Given this list of marker genes KLHL9, ZBTB20, MOB4, MTX3, PPP2R1A, ANKRD50, TPM1, TP63 (NCBI Gene Id 8860), CNR1, EEF2K, MCAM, CCDC6, TIMM23B, PHF21A, SELENOT, STAT5A, SLC5A8, RNF216, NACC2, DENND5B, SLC35A1, DONSON, WDR26, HAUS2, SSBP2 (NCBI Gene Id 51492), CCDC184, SLC25A2, ATXN7L3B, ZNF770, SLC1A4, BAZ2A, WDR82, HSPA13, NOS1 (nitric oxide synthase 1), RASL12, NAT8L, HIPK2, ZNF740 (NCBI Gene Id 283337), ADAT2, C3orf80, MAPT, IL36G, SYT17 (synaptotagmin 17), ZNF346, NDC1, BRD3, CDK12, CLN6, CD2AP, JAKMIP3, ASH1L, RNF185, STYK1, MC2R, SOCS6, MEGF9, BTNL9, TCEAL7, PCK1, PUM2, AFDN, FOXJ3, CLEC12A, TRIM45, ZFX, NOTCH2NLA, KCNC4, KCNH5, UGT8 (NCBI Gene Id 7368), ACYP2, TM9SF3, SGIP1, ARHGEF4, ABL2, TNRC6C, ASXL1, STAM2, ZXDA, LY6G5C, QSOX2, BNC2, HOOK1, GABRB2, STBD1, SNAP91, ACVR1, FHOD1, BMF, SLC16A9, ENSG00000275993, HPS4, SMCHD1, MLXIPL, PDK4, SDCBP, FLVCR2, COPS7B, MARF1, COL6A3 (collagen type VI alpha 3 chain), NSD3, PI15, DGKG, GNL3L, CYP1B1, ZNF428 (NCBI Gene Id 126299), EP300, GOSR2 (golgi SNAP receptor complex member 2), PNPT1, PPIP5K2, ZMAT2, ING5, TMEM201, PDE7A, GADL1, LYRM7, BHLHE40, FAR1, ZC2HC1A, OPN5, RECK, FRYL, SRGAP3, PLEKHG7, MTF2, NACC1, ADAMTS3, AKAP11, HLF, PGM2L1, ANKRD44, CEP85L, BMP2, PDGFRA, IGF2R, YIPF4, PAPOLA, TSPAN2, RAI1, PNMA8A, TMC7, SLC7A2, PLEKHH1, ENPP4, PLA2G7 (NCBI Gene Id 7941), CEP350, SERBP1, STARD13, PLA2G4A, UBTF, DNAJB9, PCGF2, MEF2D, ZNF670, PTCH1, DYNC1LI1, EFR3B, AMPD3, ABLIM1, LENG8, RNF138, SEPTIN8, USP7 (ubiquitin specific peptidase 7), SAMD4A, OFD1, SLFN13, MET, TLK2, PDZD4, CEP135, ATAD2, PRR23C, CHRDL1, TUB, LRP8, HIC2, RAB3C, DYNLL2, MED28, AFF1, CLTC, TIGIT, RPRD1A, VSTM2A, COPG2, RASGRP3, IQSEC3, CBX3, KDM5A, MACC1, RDX, PTP4A2, UTY (NCBI Gene Id 7404), SLC6A17, STX1B, SPRY3, MEF2A, RAPGEFL1, SPIN2B, PTGES, DDB1 (damage specific DNA binding protein 1), PLXNC1, ADRB1, PROX1, ZSWIM6, TAL1, LIN28B, NLRP8, PPP1R1C, FGF14, CCDC28A-AS1, SPSB4, COL25A1, TCEAL8, PTPN9, ALDH5A1, PAX7, ATE1, MEF2B, NCOA2 (nuclear receptor coactivator 2), CSMD2, FBXO4, HAPSTR1, PAPPA, SCN4A, YTHDC1, NLRP11, ZNF529, HYCC2, CNTN3, MBOAT2, PNPO, ASAH2B, SLC5A7, TFCP2, SCLT1, CRLF3, DNAJB11, PTPRJ, LEMD3, GID4, NYAP2, CHUK, GPR63, C1orf216, PDE1A, NPTX1, DCAF12 (NCBI Gene Id 25853), SYNPO2, GSK3B, SYTL4, JUND, TNFRSF21 (TNF receptor superfamily member 21), KSR2, PTGFRN, VGLL4, SEC63, LSM14A (LSM14A mRNA processing body assembly factor), STK36, GRIK2, SV2A, P2RY1, WDR3, CYP4B1, SLC6A19 (solute carrier family 6 member 19), KIAA0232, POLR1G, KIF13A, TENT5A, FOXK1, RIMS1, SLC39A2, MTMR9, ZNF536, RTF1, RGS7, CACNB2, NPTXR, KCNK9, ADPRH, SEPTIN3, ZNF483, SIN3A, SATB2 (NCBI Gene Id 80104), NEK7, ZNF557, SPOPL (NCBI Gene Id 339745), PLCXD3, NDUFA5, NFYC, PIAS1, MMS22L, SLC25A37, TFAM, NRG3 (neuregulin 3), ILRUN, UBR3, CCDC186, NDUFS2, TMEM67, SLC25A44, SRF, TNIP3, EPHA5, CNTNAP2, MUC15, SOX9, SRRM4, FXYD6, ARHGAP12, FAM180B, UNC13A, MYADM, RNF38, RNF19A, DOCK4, TMEM79, VAPA, PDP1, USP37, SLC1A5, YWHAQ, SP1, KIF3C, CANX, UQCC1 (NCBI Gene Id 55245), RORA, REEP3, OLFML2B, CISD2, ERO1A, GRIK3, NET1, IL13, NRARP, GEMIN8, SPIRE1, PLCL1, SLC25A46, DTX4, SYT2, BAHD1, NAMPT, RBM41, ZNF33A, CPNE8, DCBLD2, MLLT6, NEURL1B, BACH1, ENO2, PTPN3, SNRK (SNF related kinase), SCN8A, TP53BP1, SYNPO2L, NECTIN4, CSNK1G3, FAM184A, ITGB6, CACNG8 (NCBI Gene Id 59283), MFSD2A, ESM1, ABHD18, NAB1, CDC73, PIGS, PHIP, DIRAS1, EBF2, POLR1F, FAM53C, IBA57, GNA14, MYO16, ZBTB4, DESI2, ELK4, MOB3C, SLC41A2, TNFSF9, TNFSF4, ELOF1, RAP2B, CBX2, PABPC1L2A, SRCIN1, TMEM80, EFNA5, GPR180, MMAB, MBNL3, FBXW11, HMGB2, DCAF7, ZNRF2, CRY2, ADPGK, CREBZF, DNM3, CPA4 (NCBI Gene Id 51200), SKIL, BCL11B, LHFPL4, DOK6, ZC3H12C, BRD10 (bromodomain containing 10), GNA12, SCG2, SH3TC2, CBL, DLGAP4, RAD54L2, DUSP6, BEND7, TPCN1, MBL2, NOS1AP, MOBP, PEAK1, TIPRL, SGPL1, PHF3, LONRF1, KDM4A, ITGAM, WDR5B, MSL1 (MSL complex subunit 1), TRABD2A, ARHGEF10, GAS7, METTL16, SLC11A2, PRUNE2, MAPK14, ZBTB42, GPHN (NCBI Gene Id 57566), ENSG00000255537, ATP13A3, ATP6V0D1, CEMIP2, PRR14L (proline rich 14 like), DSEL, CREB5, SEMA4C, SMAD2, INSR, WDR37, NECAB1, VAT1, SLFN5, TRIM2, SLC2A4RG, USF2, NSD1, CSRNP3, GGA2, PLAU, CADM3 (NCBI Gene Id 57863), PARVA, ATOH8, CCDC9, TMEM245, TMOD2, CACHD1, SLC4A7, COBLL1, BEX4, FAM131A, UBN2, GLCCI1, ZCCHC24, TENT5C, CA12, TBC1D13, SLC7A11 (NCBI Gene Id 23657), PIK3R1, NEO1, FGFR3, MAPKAPK2, MEIS2, LIFR, ANKRD34C, SMIM15, GSTM5, RUNX1, PRDM5, DENND2D, DAAM1, CSNK2A1, TIFA, LBH, OAS3, PLXNA4, KIF2A, ELK3, ZSWIM5, BSN, MINDY2, IL21R, MARCHF8, NDRG4, FBXO5, LRP2BP, RNF112, NKTR, E2F1, MED24, LILRB2, DNAL1, DYRK1A, UNC5C, HIF1AN, FASLG, TENT4B, TRIM44, C2CD2, ADAMTS4 (NCBI Gene Id 9507), NFAT5 (NCBI Gene Id 10725), UHRF2 (NCBI Gene Id 49857), MAP3K9, EYA4, SLAIN2, TBX4, OCLN, ARHGAP26, SPOCK2, ATAD1, ST8SIA1, PAK3, F11R, EPHB3, AK4, PPP2R5C, PRKCA, DPYD, ARMC10, MTCL3, OBI1, WSCD2, FAM174B, CDK6, CDC14A, SHISAL1 (shisa like 1), ADRB3 (NCBI Gene Id 94406), LANCL3, GRID1 (NCBI Gene Id 54547), EAF1, PHKA1, ZHX2, PAX5, IGFBPL1, TMEM178B, PRR27, KDM7A, MON2, CTSV, SSH2 (slingshot protein phosphatase 2), MGAM (maltase-glucoamylase), SSH1, MATN1, SLC8A1, CEP41, ZNF266, WDFY3, FBN1, PCBD2, PTBP2, GJA5, B4GALT1, TMEM196, ZBTB41, ATF7IP, CYLD (NCBI Gene Id 8010), AGPS, GARRE1, SLC6A6, USF3, MVB12B, EDNRA, SEL1L3 (NCBI Gene Id 23231), SORT1, SMG7, FRMD3, FOXL2NB, FLT1, CFAP251, EMC1, BRWD3, KIFC1, ZNF33B, SHISA5, CNOT7, DPYSL2, CLEC4D, SRC, MLXIP, ZMAT3, EFHD2, NRF1, SULF1, CENPBD1P, AMOTL1, BPNT2, ZNF585A, ASCC3, PKIB, POC1B, IGSF9, PALM2AKAP2, KLHL42, CACFD1, SMC5, UBE2H, MRAP2, CHD5, KAT7, DUSP10, GTPBP1, VPS13D, SLC36A1, AJAP1, SLC35A3, TRPS1, MED13 (NCBI Gene Id 9969), PSD4, SORBS2, INO80D, TPGS2, P2RY2, S1PR2, IL17RA, DMXL1 (Dmx like 1), CLRN1, FBXL18, CLASP1 (cytoplasmic linker associated protein 1), KIAA0408, DDHD2, MOSMO (NCBI Gene Id 730593), UNC5A, INKA2, MGAT5, DMC1, BMPER, F2R, RAPH1, RADX, COL13A1, TMEM8B, OTULINL, TCF7L1, FAXC, AURKA, HSDL1, IRS1, CHST15, ZNF493, UNC5B, CPLX2, DCX, PSD3, KHDRBS2 (KH RNA binding domain containing, signal transduction associated 2), SPTA1, ATP9A, PAGR1, CTBP2 (NCBI Gene Id 87435), SLITRK4, SEMA6D, FOXP1 (forkhead box P1), CYRIA, CYP26B1, KCNA4, AQP3, EGR3, NR2C2, ANAPC4, GNAI1, GNB4, ZDHHC22, CLEC16A, PHAF1, AAK1, GSPT2, SLC30A3 (NCBI Gene Id 7781), CALHM5, API5, OVOL1, AK2, JADE1, CYP24A1, KCTD11, VEGFA, HSD17B13, NCOA3, EME1, PTPN4, VAMP2, RAP2A, PGAP1, DDX5, CERS5, TGFB2, MSX2, SYN2, PPP1R13B, THAP11, PTEN, PCDHB13, RDH10, CLSTN3, RNF217, FBXO41, ANKFY1, KDM3B, ZNF264, NPAS3, CENPI, IRX2, PROSER2, SFN, HEMGN, EN2, FAM78B, PPM1H, SLC35E3, REEP4, BACH2, AFF4, RGMB, KIAA1143, SGK1, RAB6B, TPPP, CD19, ARNT, UCHL5, GPX6, CHIC1, GRB2, SAR1B, RNF144B, PPARGC1B, PRSS23, TFAP2C, SGCD, STARD8, ANKRD49 (ankyrin repeat domain 49), DIDO1, TNPO1, RMND5A, LAMP2, C21orf91, SIAH1, PCBD1, PTBP3, PCSK2, TBC1D2B, TMEM35A, KMT2D, TIMM10B, PHEX, CCN2, LSAMP, MYSM1, MYLK, KLF6, KCNJ10, HSPE1-MOB4, FOXO1, SYT1, CACNA1B, NUS1, VAPB, CYP2R1, PLXDC2, NBEA, NOG, ADAMTS9, BMERB1, ZYG11B, RAB1A, CBLN4, ZBTB18, PHF6, TNIP1, AMOT, FAM120C, PARD3B, BGN, SBNO1, ETS1, GOLGA7B, PPP2R2C, THUMPD1, USP31 (ubiquitin specific peptidase 31), KCNJ12, ARIH1, USP9Y, SLC39A10, LARP4, SH3GL2, TMEM30B, HIPK1, KIF5C (NCBI Gene Id 7860), METAP1, FAM219A, MARCHF5, CYFIP1, STRN, PLEKHA2, LARP4B, KIAA0040, ZNF281, SLF2, ZC3H12B, HUNK, NRP2, CCDC85A, ZNF629, GRK3, KCNK10, DPY19L3, BRD8, ZFAND6, RBPJ, GALNT17, PDE3A, WDR72, NPAP1, ATF2, CNOT6, MDGA1, NR6A1, PAK6, VRK3, SLC25A12, SH3PXD2A, BCL2L11, ZBTB2, NHS, PCNX1, ATP2A2, OTUD7B, EIF4E2, ZNF736, ZDHHC21, PPIC, RNF19B, JUNB, ITGB3, FOXF2, KANSL1L, PLPP1, WT1, ISCU, ADAM28 (ADAM metallopeptidase domain 28), ARMC9, BTLA, CLN8, IGF1R, NLK, TMEM108, AP1G1, JARID2, ZER1, ATG10, AFF3, SPINT3, MPP2, ANKLE1, VAC14, ATF1, NAV1, ELAVL4 (ELAV like RNA binding protein 4), TMPRSS13, NUFIP2, SPIN1, CD93, ZNF562, PHLDB2, PPM1B, NRIP1, JAK2, SEC31A, CRLS1, KLHL3, ADAMTS6, CDCA3, FBXO45, FGF9, KPNA4, ITGBL1, DUSP22, PLET1 (placenta expressed transcript 1), USH1G, STMN4, DTNA, PINX1, SPATA17 (spermatogenesis associated 17), CD36, DENR, PTPRC, CADM2, STK3, MAP3K2, RNF121, SSR1, LAMTOR3, FRAS1, TNRC6B, TP53INP1 (NCBI Gene Id 94241), PKNOX1 (PBX/knotted 1 homeobox 1), FAM216B (NCBI Gene Id 144809), LFNG, ARL8B, TPTEP2-CSNK1E, PIP4K2A, NEXMIF, SLC12A2, CXXC4, STK17B, PCDH9, MCTS1, AFF2, SLC25A22, DAZAP2, STAT5B, ZNF549, SHB, XKR6, GSN, IKZF2, TMEM68, MAP4, RNF11, SLC44A1, FEZF1, KCNN3, CYB5R4, LCORL, IMPG1 (NCBI Gene Id 6673), KIF21B, NUP58, CELF1, ARF3, IPO5, CRKL, TBCK, EPHA4, SLC35B4, KCNB1, LMX1A, MAP3K21, SENP7, ONECUT2, VENTX, PITPNB, STRBP, CCPG1, ZFP14, RIMS3, G3BP1, GABPB2, TIMM10, ARHGEF15, E2F3, SLC6A14, CRIM1, SYT15, ACVR2B, ZNF134, MAPRE1, PLAG1, RALGPS1, EVI2A, TMEM132B, USP27X, STAG1, FIGN, SP6, CARF, UNC80, FGD1, CCP110, GRIPAP1, ZBTB34, TRIO, SPN, PDCD6IP, EPG5, HOXA5, RABGAP1, OTULIN, UMPS, SOCS7, ATXN7, SMAD6, PLCXD1, ZKSCAN4, FHIP2A, RASSF2, DBT, RABL3, CPSF6, DSTYK, KLHL2, ADCYAP1R1 (ADCYAP receptor type I), NDUFS1, CSNK1E, HHIP, SIGLEC15, DLC1, SMCO4, PPARGC1A, S1PR3, NHLRC2, SPEN (NCBI Gene Id 348488), PARN, PRKX, SIK1, TSEN34, PAX3, LINC02898, PNPLA2, BLCAP, AMIGO1, GASK1A, CORO1C, AMMECR1, ILKAP, CASZ1, RHBDL3, CTTNBP2NL, YWHAB (NCBI Gene Id 7529), HDAC7, here is a description of the gene set: species: Homo sapiens Genes predicted to be targets of miRBase v22 microRNA hsa-miR-8485 in miRDB v6.0 with MirTarget v4 prediction scores > 80 (high confidence targets). from publication Chen Y, Wang X (PMID 31504780) Human Gene Set: MIR8485